The following is a description of a gene set: from publication Chen Y, Wang X (PMID 31504780) Human Gene Set: MIR3921 Genes predicted to be targets of miRBase v22 microRNA hsa-miR-3921 in miRDB v6.0 with MirTarget v4 prediction scores > 80 (high confidence targets). species: Homo sapiens, and this is the list of marker genes: WDFY2, SLC16A8, CEACAM6, SH3PXD2A, ZNF248, GABRR2, TMEM144, FOXJ2, ANKRD53, SEMA3G, EPHB2, SGCB, TMEM116, SDF2, G6PC2, MXD1, UPF1, PEA15, VASN, TTC17, KCNQ3, RASSF6, SLC14A1, VAV3 (NCBI Gene Id 10451), STARD5, SEC14L3, ZNF544, CCM2, CNOT9, DHCR24, CEMIP, FMNL3, RPE65, P2RX7, PPP1R3G, MAPK1IP1L, OSBPL3, NLRP5 (NCBI Gene Id 126206), PPP4R1, RMI2, TMEM241, TACR2, HIF1A, PLEKHG4, NUBP1, PLXNA4 (plexin A4), ZNF322 (zinc finger protein 322), BMP2, CMTR1, SLC35C2, AHCYL1, C1QTNF5, CYP8B1, LVRN, KCNIP1, ZFX, HIC2, LYRM9 (LYR motif containing 9), ST8SIA5, DEFB132, NPAS3, POMGNT1, NUDCD3, ZDHHC21, MARCHF6, ZBED4, RUBCN, KLF12, FAM124A, AMN1, HOMER1, PTPN12, UBE2E3, TREM1, CD4, CERCAM, PLPPR4, WDR48, CNTN4, IRGQ, HES5, UMODL1, KAT6A, TNFAIP3, TSHZ1, CFAP65, SET, TRABD2A, WIPF3, DCUN1D5, CHST14, SLC24A4, RNF222, EIF3J, LRRC3, EGR2, ERP27, CAMK1D, MTX3, BNC2, DSCAML1, FOXC1, MLLT11, TNFRSF10D, NLRP2B, CPS1, NYAP2, ZFYVE26, TXNIP, ERLIN1, KRTAP8-1, APIP, ZSCAN12, MEA1, JMJD8, SGO1, C1orf21, PIAS1, LIPT2, KCNJ12, MFRP, RIPK1, AQP5, ARID2, RORC, SAR1B, ZNF12, JPH4, ASXL3, ZNF398, TMEM154 (NCBI Gene Id 201799), NCOA7, ZEB1, ANKFY1, STK4 (serine/threonine kinase 4), MBD6, ARID4A, SLC44A1, PDS5A, HYCC2, PPP2R3A, HHEX, SSBP4, WBP1L, SZRD1, CALB2